Given this list of marker genes VSIG1, B3GNT6, ANXA10, MARCKSL1P2, MSMB, GMDS, FAM177B, ERN2, LYZ, CXCL5, SLC9A4, FAR1, SLC9A2, MUC6, CXCL3, ARL14, TMEM238L, BMP2K-DT, RNU5B-1, MUCL3, IL17C, CLASP1-AS1 (CLASP1 antisense RNA 1), UGT2B15, SLC30A4-AS1, C16orf89, TSPAN15, CREB3L1, PRKCI, TFF2, ENSG00000262966, CSF3, PDPK2P, AGR2, SAMD12, FOXQ1, LIPF, RFLNA, MUC5AC, KRT18P55, TEX14, A4GNT, ERO1A, FBXW11, GPRC5A, CAPN9, DUOX2, GKN2, SPDEF, FUT9, ENSG00000222001, PSPHP1, PGC, LRRC31, MYADM-AS1, here is a description of the gene set: The gene expression program underlying the specification of human cell types is of fundamental interest. The study authors generated human cell atlases of gene expression and chromatin accessibility in fetal tissues. For gene expression, the study authors applied three-level combinatorial indexing to >110 samples representing 15 organs, ultimately profiling ~4 million single cells. The study authors leveraged the literature and other atlases to identify and annotate hundreds of cell types and subtypes, both within and across tissues. Our analyses focused on organ-specific specializations of broadly distributed cell types (such as blood, endothelial, and epithelial), sites of fetal erythropoiesis (which notably included the adrenal gland), and integration with mouse developmental atlases (such as conserved specification of blood cells). These data represent a rich resource for the exploration of in vivo human gene expression in diverse tissues and cell types. Human Gene Set: DESCARTES_MAIN_FETAL_GOBLET_CELLS species: Homo sapiens Marker genes curated from the annotated cluster as represented in the Descartes Human Gene Expression During Development database. from publication Cao J, O'Day DR, Pliner HA, Kingsley PD, Deng M, Daza RM, Zager MA, Aldinger KA, Blecher-Gonen R, Zhang F, Spielmann M, Palis J, Doherty D, Steemers FJ, Glass IA, Trapnell C, Shendure J (PMID 33184181)